The following is a description of a gene set: Mouse Gene Set: MIR_6898_3P studied in species Mus musculus from publication Chen Y, Wang X (PMID 31504780) Genes predicted to be targets of miRBase v22 microRNA mmu_miR_6898_3p in miRDB v6.0 with MirTarget v4 prediction scores > 80 (high confidence targets)., and this is the list of marker genes: Dach1, Cisd2 (CDGSH iron sulfur domain 2), Fam174a, Mospd2, Ctdspl2, Marveld3, Atp6ap2, Slc17a6, Tfr2, Rab3c, D5Ertd579e, Mplkipl1, Shprh, Nell1, Mfsd2a, Cutal, Sars2, Impg2, Ist1 (NCBI Gene Id 71955), Lrig1, Agfg2, Map1b, Chic2, Mex3a, Usp1, Mfng, R3hdm1, Scai, Gria4, Scoc, Parvb, Zfp937, Cstb, Gtf2a2, Fas, Kif21a, Dcdc2c, Fosl1, Slain1, Nt5c2 (5'-nucleotidase, cytosolic II), Lrrc34, Slc35f6, Rab5a, Ttr, Abcd3 (ATP-binding cassette, sub-family D member 3), Six3, Gosr1, Cmah, Tmprss15 (NCBI Gene Id 353032), Tspyl5, Alms1, Habp4